Given this list of marker genes FURIN, CD4, CH25H, P4HB, BSG, HMGB1 (NCBI Gene Id 3146), TRIM5, NECTIN2, TRIM21, HS3ST5, LGALS9, SMPD1, TRIM38, CD74, TRIM25, TMPRSS4, TMPRSS2, TRIM62, HLA-DRB1, TRIM11, LGALS1, here is a description of the gene set: Human Gene Set: GOBP_REGULATION_OF_VIRAL_ENTRY_INTO_HOST_CELL studied in species Homo sapiens Any process that modulates the frequency, rate or extent of the viral entry into the host cell.